The following is a description of a gene set: studied in species Homo sapiens SHC-related events triggered by IGF1R Human Gene Set: REACTOME_SHC_RELATED_EVENTS_TRIGGERED_BY_IGF1R, and this is the list of marker genes: GRB2, KRAS, SHC1, IGF2, IGF1R, IGF1, NRAS, HRAS, SOS1